The following is a description of a gene set: Human Gene Set: GOMF_CATECHOLAMINE_BINDING Binding to catecholamine. species: Homo sapiens, and this is the list of marker genes: ADRB3, ADRA2C, ADRA2A, GPR143, DRD4, DRD2, ADRB2, DRD5, RNLS, SLC6A3, DRD1, ADRA2B